Given this list of marker genes CCDC134, ZMPSTE24, NF1, FGFR1, CBFB, MET, EFNB1 (NCBI Gene Id 1947), MYF5 (myogenic factor 5), WNT7A, here is a description of the gene set: A pathologic entity characterized by a developmental defect in a long bone leading to bending and pathologic fracture, with inability to form a normal bony callus with subsequent fibrous nonunion, leading to the pseudarthrosis (or \false joint\). Pseudoarthrosis Human Gene Set: HP_PSEUDOARTHROSIS studied in species Homo sapiens